The following is a description of a gene set: Mouse Gene Set: chr3A2 studied in species Mus musculus, and this is the list of marker genes: Armc1, Cpb1, Gm6141, Gm17771, 4632415L05Rik, Mtfr1, Crh, Cp, Gm18864, Dnajc5b, Pgk1-ps3, Cpa3, Pde7a, Gm30341, Trim55, Hltf, 1700064H15Rik (NCBI Gene Id 73424), Gm18426, Gyg1, Gm7442, Hps3, Agtr1b, Mir7007